Given this list of marker genes ARFGEF2, PIGV, PI4KA, DCX, CDKL5, ATN1, DOCK7, PGAP3, CLTC, VAMP1, PIGS, ALG14, STXBP1, ATP6V1A, TRIM8, CNTNAP2, CACNA1H, PCDH19, ALG3, PIGT, SYT1, HID1, SRPX2, GOLGA2, GRIN2D, OTUD7A, PNKP, SLC25A22, KCNMA1, NSF, NPRL3, GNB1, NTRK2, ASPA, ARV1, CNKSR2, SLC5A7, NEDD4L, PIGO, PTS, SCN2A, GRN, DPM2 (NCBI Gene Id 8818), SLC6A1, NECAP1, ERMARD, CNPY3, MDH1, ALG11, PIGQ, ATP7A, STX1B, AIMP2, PIK3CA, SCN1A, KCNA1, GOSR2, DHDDS, NUS1, UFC1, GNB5, ABAT, SV2A, NPRL2, MPDU1, GLUD1, CACNA1A, AARS1, TBCK, PSAT1, NAXD, PTPN23, KCNQ3, GUF1, YWHAG, GCSH, HCN1, SCN3A, PI4K2A, LONP1, SCN9A, PRKAG2, WDR45 (WD repeat domain 45), CACNA2D1, COX4I1, EEF1A2, CHD2, FGF12, ALG2 (ALG2 alpha-1,3/1,6-mannosyltransferase), YEATS2, SPTAN1, CDK5, VARS2, SLC12A5, SAMD12, MOGS, EFHC1, ZNF526, C1QBP, PRNP, PIDD1, SLC35A2, PPFIBP1, PHACTR1, SNAP25, CASK, DNM1, KCNB1, DOLK, GABBR2, SETBP1, SLC1A2, ALDH7A1, GABRB3, IARS2, ARFGEF1, NACC1, ARX, FGF13, TRAPPC12, AP2M1, PIGL, CACNB4, PIGY, NHLRC1, GABRG2, CAPRIN1, MYO9A, SETD1B, ALDH4A1, EPM2A, TRAK1, ESAM, SYNJ1, HIBCH, CUX2, GRIN2A, KCNQ2, GABRA5, MFF, GAD1, FOXG1, GABRB2, PDHA1, BRAT1, CLN8, KCNC2, MED17, ATP6V0A1, CACNA1B, PIGP, WWOX, ST3GAL3, ROGDI, SYT2, TGFB1, COQ4, PGAP2, PLCB1, AFG2A, CTNNA2, SLC38A3, TBL1XR1, FRRS1L, HMGCL, GRIN1, GRIN2B, SMC1A, SLC1A4, GRM7, DMXL2, SCN8A, KCNT1, PRICKLE1, NEUROD2, CELF2, CCDC88A, ALG13, ATP1A2, GLS, CUL3, FBXO28, CACNA1E, DEPDC5, KCNA2, MTOR, CAMSAP1, ATAD1, MT-TL1, APC2, ATXN10, PCDH12 (protocadherin 12), GLYCTK, SLC25A1, TBC1D2B, KCNC1, CPLX1, KCNT2, PLPBP, AP3B2, FZR1, D2HGDH, SLC39A8, RUSC2 (NCBI Gene Id 9853), PAFAH1B1, NARS2, TUBB2A, SCARB2, JRK, AASS, MGAT2, GABRB1 (NCBI Gene Id 2560), SLC32A1, SATB1, CDK19, SIK1, GABRA1, PLAA, TIMM50, DPAGT1, ASNS, GABRA2, UPB1, PPP3CA (protein phosphatase 3 catalytic subunit alpha), ADGRG1, CPA6, EXOC8, AGRN (NCBI Gene Id 389836), SLC13A5, SLC2A1, AMT, PACS2, STARD7, PARS2, ADGRV1 (adhesion G protein-coupled receptor V1), TBC1D24, SYNGAP1, SCN1B, SZT2, KCNJ11, CILK1, SPTBN1, PIGW, CYFIP2 (cytoplasmic FMR1 interacting protein 2), ZNHIT3, CLCN2, NEXMIF (NCBI Gene Id 340533), ABCC8, SLC25A46, GNAO1, GFM2, UBA5, CHAT, ACTL6B, PNPO, ATP1A3, UGDH, NDUFAF8, DNM2, HCFC1, AKT3, PRRT2 (proline rich transmembrane protein 2), CSTB, DALRD3, PIGA, SLC18A3, IER3IP1, COL13A1, PHGDH, GABRD, NF1 (NCBI Gene Id 646021), ZNF148, here is a description of the gene set: Human Gene Set: HP_EEG_WITH_GENERALIZED_EPILEPTIFORM_DISCHARGES studied in species Homo sapiens EEG discharges recorded on the entire scalp typically seen in persons with epilepsy. EEG with generalized epileptiform discharges